Given this list of marker genes Smarcd2, Capzb, Add3, Becn1, Smad7, Gba1, Nckap5l, Gabarapl2, Smarcb1, Ogfod1, Mid1ip1, Tmod1, Smarcd3, Ubqln4, Akap5, Ccdc88c, Sptan1, Hdgfl3, Nsf, Dmtn, Lmod2, Smn1, F2rl1, Map1a, Htr1a, Vps16, Oga, Ttbk2, Vcp, Myc, Nav3, Myh9 (myosin, heavy polypeptide 9, non-muscle), Per2, Tmod3, Capza2, Lima1, Chmp1b2, Hdac6, Arid1a, Apc2, Afg2b, Chmp2a, Add1, Arhgef2, Kif2b, Etf1, Abce1, Map6d1, Cfl1, Ccn2, Swap70, Vamp8, Napa, Chmp6, Apc, Vil1, Smcr8, Map2, Nrg1, Uvrag, Mtrfr, Flii, Gas2l2, Katnb1, Spef1, Arhgef1, Napb, Bmyc, Epg5, Stmn1, Tmod4, Jmjd4, Vmp1, Smarcd1, Rdx, Rubcnl, Calm1, Avil, Camsap2, Chmp2b, Insr, Calcoco2, Carmil1, Irgm2, Pex14, Pik3ca, Wnk1, Calm2, Diaph3 (NCBI Gene Id 80466), Adrb2, Pik3r4, Arpc2, Tecpr1, Pik3c3, Clec16a, Kif5b, Dnajc17, Traf2, Tmem39a, Nckap5 (NCK-associated protein 5), Smarce1, Eif5a2, Chmp3, Vps33a, Evl, Lix1, Atg14, Chmp5, Gsn, Rpl23, Cfl2, Dnajc6, Asph, Spast, Add2, Scin, Eif5a, H2ac25, Vill, Trim54, Fgf13, Capza1 (NCBI Gene Id 12340), Ccsap, Chmp4c, Mrpl58, Arid2, Snap29, Faf2, Rubcn, Snx14, Carmil2, Setx, Plek, Nes, Taok1, Chmp4b, Pif1, Irgm1, Kif21a, Tpx2, Zfand1, Cebpg, Tbc1d25, Calm3 (calmodulin 3), Vps4a, Cib1, Cltc, Nedd1, Synj1, Pex5, Rp1, Dyrk3, Zmpste24, Eef2k, Atad2b, Map1b, Stmn2, Lmod1, Igf1r, Wdr1, Atp2a2 (ATPase, Ca++ transporting, cardiac muscle, slow twitch 2), Bbof1, Scaf4, Svil, Mtrf1, Spta1, Dstn, Lmod3, Sptb, Lix1l, Supt16, Mtrf1l, Ckap2, Atg5, Shfl, Snapin, Twf1, Tnf (tumor necrosis factor), Gak, Gabarapl1, Chmp7, Aqp2, Dbnl, Lamp2, H2bc1, Tom1, Smarcc2, Atxn7, Kif24, Klc1, Cracd, Kif19a, Capza1b, Pym1, Kif18b, Stmn4, Grwd1, Mical1, Pdxp, Scaf8, Eps8, Chmp1b, Elp6, Phf23, Bnip3, Atad2, Aurkb, Ssrp1, Map1lc3a, Bmerb1, Mtpn, Trpv4, Smarcc1, Smarca4, Mid1, Wdr47, Cln3, Ddit4, Gas2l1, Actn2, Sema5a, Specc1l (NCBI Gene Id 75003), Gspt2, Shroom2, Atg12, Ubqln1, Tpm1, Sh3bp1, Trim21, Clasp2, Sgk1, Map1s, Camsap1, Kif2c, Mical3, Upf1, Kif18a, Hspa8, Sptbn1, Gabarap, Stmn3 (NCBI Gene Id 99032), Mical2, Camsap3, Capg, Gspt1, Capza3, Vps4b, Tmod2, Igtp, Tfip11, Chmp1a, Stx17, Irak3 (NCBI Gene Id 73914), Htt, Rhoa, Kif14, Mcoln1, Eml4, Tnp1, Ppp1r9b, Twf2, Map1lc3b, Mfsd8, Hemk1, Plekhh2, Clasp1, Fyco1, here is a description of the gene set: species: Mus musculus The disaggregation of a protein-containing macromolecular complex into its constituent components. Mouse Gene Set: GOBP_PROTEIN_CONTAINING_COMPLEX_DISASSEMBLY